Given this list of marker genes Gfer, Hsp90aa1, Slc9a1, Rsrc1, Mir208b, Ets1, Vps54, Slc1a3, Endog, Pla2g4a, Ehmt1, Alpl, Kdm5b (lysine demethylase 5B), Trp53, Hdac8, Ppp2cb, Abcb1a, Jak1, Hpse, Zc3h8, Gria1, Ezh2, Pla2g4f, Hyal2, Ciita, Id1, Crip1, Cyb5r4, Hyal1, Kat7, Kdm6b, Star, Hnf4a, Hif1a, Hyal3, Dusp18, Rpl23, Jak2, Ehmt2, Hdac2, Mef2c, Kdm1a, Scn3a, Mdm2, Cdkn1b (cyclin dependent kinase inhibitor 1B), here is a description of the gene set: Mouse Gene Set: GOBP_RESPONSE_TO_ANTIBIOTIC Any process that results in a change in state or activity of a cell or an organism (in terms of movement, secretion, enzyme production, gene expression, etc.) as a result of an antibiotic stimulus. An antibiotic is a chemical substance produced by a microorganism which has the capacity to inhibit the growth of or to kill other microorganisms. species: Mus musculus